The following is a description of a gene set: studied in species Homo sapiens Human Gene Set: GOBP_HINDBRAIN_MORPHOGENESIS The process in which the anatomical structure of the hindbrain is generated and organized. The hindbrain is the region consisting of the medulla, pons and cerebellum. Areas of the hindbrain control motor and autonomic functions., and this is the list of marker genes: CBS, ABL1, LHX5, ZNF365, DLL1, TRNP1, ENSG00000274276, SERPINE2, TTC21B, SMO (NCBI Gene Id 6608), DAB1, GSX2, LHX1, GNPAT, HERC1 (HECT and RLD domain containing E3 ubiquitin protein ligase family member 1), RORA, HSPA5, PROX1, HES1, MAP2K1, LDB1, TTLL1, KNDC1, COQ8B, GRID2, TUBA1A, FAIM2, DLC1, SPTBN2, NRXN1, OPHN1, GLI2, WNT1, CBLN1, WNT7A, CDK5, AGTPBP1, FOXP2, SLC25A46, GBA1, CEND1, KIF14, PTPN11 (NCBI Gene Id 84990), COMT, GLI1 (NCBI Gene Id 2735), SKOR2, ATP7A (NCBI Gene Id 613259), WHRN (NCBI Gene Id 8016)